Given this list of marker genes Gm9103, Dmrtc1c1, Slc16a2, Rtl3, Gm14857, Cxcr3 (C-X-C motif chemokine receptor 3), Gm5392, Gm14841, Gm9159, Gm9143, Gm6292, Magt1, Gm4991, Gm23378, Tent5d, 1700121L16Rik, Gm379, Gm14839, Gm22090, Xist, Tex11, Pabpc1l2b, Gm9078, Rtl5, Gm16471, P2ry10, Gm7117, Gm4779, Lpar4, Gm6285, Gm16511, 1700031F05Rik, Gm3858, Gm9115, Gpr174, 4933401B06Rik, Nap1l2, Fnd3c2, Nhsl2, Rps12-ps1, 5730416F02Rik, Gm9785, Gm14847, Tpt1-ps6, Tsix, Gm14868, Gm9218, Magee2, E530001F21Rik (RIKEN cDNA E530001F21 gene), Gm5166, Pgk1, Cypt2, Dmrtc1a, Gm9208, Cdx4, Nono, Gm25828, Gm5127, Gm614, Gm14901, Gm14856, Gm14840, Cox7b, Itm2a, Gm14855, Fgf16, Gm4784, Gm14852, Fam236d, Gm9670, Gm14882, Gm24061, Snx12, Gm9157, Gm378, Rpl30-ps9, Gm19200 (predicted gene, 19200), Gm14824, Phka1, Uprt, Gjb1, Gm9166, Atp7a, Mir374b, Gm14858, Slc7a3, Gm14859 (predicted gene 14859), Dmrtc1c2, Il2rg, Gm26020, Gm9126, Mir325, Gm9050, Chic1, Gm14833, Taf9b, Gm9119, Gm14878, Atrx, Gm24622, Pbdc1, Sh3bgrl, Chmp1b2, Gm14834, Gm23322, Rlim, Gm6238, Zdhhc15, Tsx, Cited1, Gm22430, Ftx, Gm21998, 8030474K03Rik, Gm14861, Marcksl1-ps5, Gm22266, Taf1, Gm14853 (predicted gene 14853), Hmgn5, Gm9673, Jpx, Mir374c, Gm22472, Rab9b-ps1, Brwd3, Gm14845, P2ry10b, Gm9109, Gm3928, 2810403D21Rik, Rps4x, Abcb7, Pin4, Gm6206, Gm9095, Gm3931, Gm6325, Fam236e, Magee1, Fam236c, Gm5125, Tbx22, 5330434G04Rik, Pabpc1l2a, Mir672, Gm9516, Mir421, Gm14843 (predicted gene 14843), Mir384, Fndc3c1, Gm4234, Med12, Gm9164, Nlgn3, 5530601H04Rik, Gm3943, Gm14877, Gm14879, Dmrtc1b, Gm14869, Gm6222, Gm6184, Gm9097, Cysltr1, Fam236f, H3f3a-ps1, Foxo4, Gm14854, Itgb1bp2, Zcchc13, Gm14880, Gm9200, Zmym3, Gm14881, Gm9133, Vcp-rs, Gm6377, Wmp, Nexmif, Gm5133, Tlr13, Gm14870, Gm24491, Ogt (NCBI Gene Id 77137), Gm23656, Gm14849, Hdac8, Ercc6l, here is a description of the gene set: Mouse Gene Set: chrXD studied in species Mus musculus